Given this list of marker genes EZR, SPRR1B, PEPD, CDKN1A, LY6D, TGM3, SDC1, S100A11, PPDPF, IL1RN, CSTB, CST3, NDRG1, HMGCS1, GBP6, SPRR2D, NIBAN2, CLIC3, CITED4 (NCBI Gene Id 163732), TM7SF2, CEACAM6, CRNN, PKP3 (plakophilin 3), GRN, CXCL17, PDZK1IP1 (NCBI Gene Id 10158), GJB2, DHRS1, MPZL2, KLK11, KRT6B, ALDH3B2, SLURP1, CAST, SBSN, ACTB, SPRR2A, CSTA, PKP1, TUBA1C, LGALS3, NUCB2, SERPINB3, SCEL, HSPB1, ATP6V0C, TXN, CYP2C18, P4HB, DSP, CDKN2B, CRABP2, KLK13, TSPO, CDA, ELL2, FAM3B, SERPINB4, CYSRT1, ALDH9A1, S100A8, CLDN4, PPL (periplakin), ARPC2, RAB11A, RAB10, ENDOU (NCBI Gene Id 8909), C4orf3, CALML3, MALL, RAB25 (RAB25, member RAS oncogene family), TRIM29, CLTB, TGM1, MAL, SORT1, SPINK5, RHCG, GPR15LG, SCD, A2ML1, SLPI, NCCRP1, FMO2, KRT6A, SPRR1A, ANXA1, ZNF185, FGFBP1, DSG1, DYNLT3, TENT5B, CLCA4, TUBB6, AQP3, DMKN, SPRR3, GPX3, KRT13, EGR1, CD24, DSG3, PERP, CTNNBIP1, YWHAZ, EVPL, TECR, DBI, S100A16, SOD2 (NCBI Gene Id 79099), TMSB10, ALDH3A1, S100A10, TMSB4X, GUK1, SERPINB13 (serpin family B member 13), S100A9, AHNAK, MUC21 (NCBI Gene Id 394263), JUP, MAL2, GSN, LYNX1, MGLL, LYPD3, CES2, FAM162A, DSC2, SERPINB2, KRT6C, SERPINB1, ANXA2, SH3BGRL3, GLTP, NAGK, GRHL1, IVL, CNN3, KRT4, S100A14, here is a description of the gene set: Human Gene Set: BUSSLINGER_ESOPHAGEAL_LATE_SUPRABASAL_CELLS from publication Busslinger GA, Weusten BLA, Bogte A, Begthel H, Brosens LAA, Clevers H (PMID 33691112) studied in species Homo sapiens